The following is a description of a gene set: Human Gene Set: PID_TRAIL_PATHWAY from publication Schaefer CF, Anthony K, Krupa S, Buchoff J, Day M, Hannay T, Buetow KH (PMID 18832364) TRAIL signaling pathway species: Homo sapiens, and this is the list of marker genes: PIK3CB, TNFSF10, FADD, IKBKB, TNFRSF10D, DAP3, IKBKG, RIPK1, CASP8, MAPK1, TNFRSF10B, TNFRSF10A, CFLAR, TRAF2, CASP10, MAP2K4, MAP3K1, PIK3R2, PIK3R1, PIK3R3, PIK3CA, CHUK, MAPK3, SMPD1, TRADD, MAPK8, TNFRSF10C, PIK3CD